Given this list of marker genes MTAP, LBR, GJA1, TBCE, SQSTM1, here is a description of the gene set: Patchy (irregular) changes in bone mineral density. These changes can either be patchy reduction or increase of mineral density as seen on x-rays. Depending on the pathomechanism and the underlying disease, these changes can either appear solely as reduction or increase or as a combination of both (patches of bone showing an increased density while others are affected by reduction of mineral density). Human Gene Set: HP_PATCHY_CHANGES_OF_BONE_MINERAL_DENSITY Patchy changes of bone mineral density studied in species Homo sapiens